The following is a description of a gene set: Any process that results in a change in state or activity of a cell or an organism (in terms of movement, secretion, enzyme production, gene expression, etc.) as a result of a mechanical stimulus. Human Gene Set: GOBP_RESPONSE_TO_MECHANICAL_STIMULUS species: Homo sapiens, and this is the list of marker genes: CASP8, PKD1L3, PJVK, MYC, HPN, SLC2A1, XPC, MAP3K14, PKD1, LRP11, ASIC3, MAP1B, JUP, PSPH, PECAM1, KIAA0319, KRT5, CHRNA9, SLC9A1, TEK, GCLC, MAPK8, TXNIP, TNF, SLC1A3, SERPINE2, GOT1, ASIC2, IRF1, SLC8A1, ANO3, ADGRV1, RAF1, ABHD12, TNFSF14, CRADD, PKD1L1, GPI, COL6A1, NPPA, PLEC, TLR3, TMC2, PTK2, WNT11, KCNK2, CSRP3, PKD2L1, HABP4, SLITRK6, BAD, SOST, PTCH1, JUND, STRC, FGF2, CXCL12, KCNJ2, IL13, BDKRB1, NFKB1, TNFRSF11A, EDN1, MMP2, IHH, MPO, KIAA0319L, PKD2L2, CHI3L1, KCNA1, TGFB1, CYBA, ERCC8, SOX9, FADD, KCNA5, MAP2K4, TLR4, ITGA2, FYN, RCAN1, DDR2, CASP8AP2, PDE2A, DRD2, CALB1, SLC38A2, BACE1, MDK, BMP6, NFKBIA, MAP3K2, NRXN1 (neurexin 1), SUN1, PTN, MAPK3 (mitogen-activated protein kinase 3), MAP3K1, MYD88, ATP1A2, CXCL10, TMC1, PPL, TLR8, P2RX3, MAG, HDAC3, RETN, SCEL, TCAP, KCNC1, NTRK1, PDZD7, PKDREJ, SLC26A5, MEIS2, RELA, ATAT1, GSN, ATP8A2, DCANP1, KCNQ3, KCNK4, MKKS, CDH2, NEUROG1, ATOH7 (NCBI Gene Id 54719), BAK1, MBD2, PKD1L2, REST, TLR7, ANGPT2, TNFRSF8, DAG1, ATR, KCNQ1, ANKRD1, PIK3CA, TNFRSF10B, SCN1A, COL1A1, STAT1, FOXP2, CHEK1 (NCBI Gene Id 1111), TIFAB, TMEM120A, CASP1, BCL10, CASP2, SHANK3 (NCBI Gene Id 85358), GAB1, TNC, IL1B, USP53, JUN, IGFBP2, PHF24, TRPA1, FOS, P2RX7, PTGER4, TNFRSF1A, LTBR, CD40, P2RY1, THBS1, SMPD2, POSTN, GADD45A, TNFRSF10A, PIEZO1, CCNB1, PTPN11, FAS, MMP14, LARGE1, ENDOG, TLR5, BAG3, CITED2, ANKRD23, RYR2, NRXN2, UCN, APP, GATA4 (NCBI Gene Id 2626), CAPN2, CNTNAP2, STRBP, TMEM87A, F11R, AQP1, ITGAM, STRA6, KIT, PTPRQ, PIEZO2, BGLAP, BTG2 (NCBI Gene Id 7832), BNIP3, CLCN6, PRKCA, CASP5, TUBA1A, SCX, TRPV4, MAPK14, PKD2, GDF5, DMD, HTT, CTNNB1, CHRNA10, SCN9A, WHRN, LHFPL5, CNN2 (calponin 2), TACR1, ETV1, SCN11A, ITGB3, COL11A1, TTN, CAV3, TMEM150C, GAP43, FOSB, HTR2A